Given this list of marker genes UBIAD1, VKORC1L1, VKORC1, here is a description of the gene set: species: Homo sapiens Vitamin K is a required co-factor in a single metabolic reaction, the gamma-carboxylation of glutamate residues of proteins catalyzed by GGCX (gamma-carboxyglutamyl carboxylase). Substrates of GGCX include blood clotting factors, osteocalcin (OCN), and growth arrest-specific protein 6 (GAS6). Vitamin K is derived from green leafy vegetables as phylloquinone and is synthesized by gut flora as menaquinone-7. These molecules are taken up by intestinal enterocytes with other lipids, packaged into chylomicrons, and delivered via the lymphatic and blood circulation to tissues of the body, notably hepatocytes and osteoblasts, via processes of lipoprotein trafficking (Shearer & Newman 2014; Shearer et al. Two related enzymes, VKORC1 and VKORCL1, can each catalyze the reduction of MK4 epoxide to active MK4. VKORC1 activity is essential for normal operation of the blood clotting cascade and for osteocalcin function. A physiological function for VKORCL1 has not yet been definitively established. Reactome Pathway: Metabolism of vitamin K part of: Metabolism of fat-soluble vitamins